The following is a description of a gene set: Human Gene Set: REACTOME_DEFECTIVE_CHST14_CAUSES_EDS_MUSCULOCONTRACTURAL_TYPE Defective CHST14 causes EDS, musculocontractural type species: Homo sapiens, and this is the list of marker genes: BCAN, NCAN, CSPG4, CHST14, CSPG5, DCN, BGN, VCAN